The following is a description of a gene set: Human Gene Set: REACTOME_PHASE_1_INACTIVATION_OF_FAST_NA_CHANNELS Phase 1 - inactivation of fast Na+ channels species: Homo sapiens, and this is the list of marker genes: KCND3, KCNIP3, KCND2, KCNIP2, KCNIP4, KCNIP1, KCND1